Given this list of marker genes POR, BMP1, TGFB1, IHH, POLR3A, KIAA0753, LONP1, FGFR2, PTDSS1, GNPAT, GDF5, SNRPB, SPARC, PITX1, LBR, PEX5, B3GALT6, LMBR1, FZD2, SLC26A2, CCN2, TBX15, MYSM1, NOG, MACROH2A1, MTHFS, FGFR1, FANCB, PRKG2, GNPTAB, CREB3L1, TBX5, TNFRSF11B, COL2A1, WNT7A, GPC6, FLNA, SUCLG1, ZIC3, GNAS, ATP7A (ATPase copper transporting alpha), GSC, EZH2, SRCAP, DYM, RECQL4, TBX3 (NCBI Gene Id 91834), CYP26B1, IFT122, LYSET, SALL4, FGF9, RSPO2, TRPV4, ESCO2, SHOX, DONSON, GNPNAT1, RBM8A, FLNB, STX16, ALG12, TGDS, LAMA5, AGPS, RNU4ATAC, TONSL, here is a description of the gene set: studied in species Homo sapiens Human Gene Set: HP_ABNORMAL_HUMERUS_MORPHOLOGY Any structural anomaly of the structure of the humerus (i.e., upper arm bone). Abnormal humerus morphology